The following is a description of a gene set: Genes down-regulated in monocytes (6h): muramyl dipeptide versus M. tuberculosis 19 kDa lipopeptide. species: Homo sapiens Human Gene Set: GSE34156_NOD2_LIGAND_VS_TLR1_TLR2_LIGAND_6H_TREATED_MONOCYTE_DN human blood monocytes were isolated, activated and harvested at several timepoints In this study, we identified genes that were differentially expressed in human monocytes activated with eiter NOD2L and/or TLR2/1L. from publication Schenk M, Krutzik SR, Sieling PA, Lee DJ, Teles RM, Ochoa MT, Komisopoulou E, Sarno EN, Rea TH, Graeber TG, Kim S, Cheng G, Modlin RL (PMID 22447076), and this is the list of marker genes: ATP6V1B2, PTAFR, CYBRD1, RIN3, LILRA6, CLIC1 (NCBI Gene Id 257617), EWSR1 (NCBI Gene Id 2130), NCF4, FTL, NCOA4, MAP4K3, ZNF385A, LILRB2, TLN1, GBA1LP, WARS1, FCGR2C, ABCD1, TLR2, PITPNA, PITPNM3, EMILIN2, NDST3, AATK, CD93, ATP10B, CAPG, ZNF697, C3AR1, GPR157, DOK3, KYNU, GK3, GM2A, EPB41L3, SGK3, IGSF6, TYROBP, HCAR3, MAFB, ACTB, SIRPA, RRBP1, ELF4, COPRS (NCBI Gene Id 95076), GASK1B, BCAT1, ACVRL1, HLA-DRB4, P2RY14, CREG1 (cellular repressor of E1A stimulated genes 1), LGALS3, AQP5, BLVRB, GPR101, CXCL1, MBOAT7, RAB7A, LRP1, TFE3, RAB31, SULF2, LHFPL2, FCAR, ACSL1, MGST1 (NCBI Gene Id 4257), CD151, PLEKHO2, MSR1, GNB4, MPEG1, CTSL (NCBI Gene Id 1514), ASAH1, TNS3, TGFBI, LMO2 (LIM domain only 2), CD86, LACC1, SLC8A1-AS1, MYOF, CORO1C, CXCL16, CYBB, CTSD, KIF13A, CHST15, SLC16A6, HPSE, SPACA3, PLA2G2A, LINC00879, TMEM144, DMXL2, NRP2, CALML5, SAT1, GNS, TMCC3, ADAM28, FANCL, PLXNB2 (NCBI Gene Id 23654), GPX1, FOXP1-IT1, ST3GAL4, MARCKS, ANO6, ABCA1, ZNF787, LINC01016, RBM47, CYTH3, KCNJ2, NCAPG2, LINC01854, SEMA3F, LIMS1, IRF5, ADGRE3, NCF1C, FERMT3, ADGRE2, TIMP1, CXCL8, CD163, VCAN, KLRB1, PGD, IFI30, DAPP1, VPS37C, NCF2, RNF152, LINC01343, GRN, LAMA4, FLOT1, HAVCR2, CD14, CCR1, GAST, P2RX7, ATP13A3, GK (NCBI Gene Id 2710), CTSZ, CXCL3, BRI3, ANXA5, P2RX4, CARD19, ANPEP, OS9, LILRB3, SYNGR2, TMEM51, PLAU, SLC43A2, SLC25A37, FAM20C, GSDME, CSF2RB, LGALS9, PPARG, IL13RA1, LYN (NCBI Gene Id 4067), SLC35E4, FPR2, GLUL, NADK, C15orf48, IL31RA, RNF130, RIN2, VDR, KCNQ3, LILRB4, SIGLEC9, SCN2A, SLAMF9, PSTPIP2, DSE, OPTC, MPP1, ADAM9, CFC1, TFEC, TRPS1, TMEM158, QSOX1, ACOT6 (acyl-CoA thioesterase 6), LGALS2, CLIC4, VEGFA, FCGR2A, DKK4, PILRA, HCK, PTPN12